The following is a description of a gene set: Little is known about how differentiating cells reorganize their cellular structure to perform specialized physiological functions. MIST1, an evolutionarily conserved transcription factor, is required for the formation of large, specialized secretory vesicles in gastric zymogenic (chief) cells (ZCs) as they differentiate from their mucous neck cell progenitors. Here, we show that MIST1 binds to highly conserved CATATG E-boxes to directly activate transcription of genes, including those encoding the small GTPases RAB26 and RAB3D. We next show that RAB26 and RAB3D expression is significantly downregulated in Mist1(-)(/)(-) ZCs, suggesting that MIST1 establishes large secretory granules by inducing RAB transcription. To test this hypothesis, we transfected human gastric cancer cell lines stably expressing MIST1 with red fluorescent protein (RFP)-tagged pepsinogen C, a key secretory product of ZCs. Those cells upregulate expression of RAB26 and RAB3D to form large secretory granules, whereas control, non-MIST1-expressing cells do not. Moreover, granule formation in MIST1-expressing cells requires RAB activity because treatment with a RAB prenylation inhibitor and transfection of dominant negative RAB26 abrogate granule formation. Together, our data establish the molecular process by which a transcription factor can directly induce fundamental cellular architecture changes by increasing transcription of specific cellular effectors that act to organize a unique subcellular compartment. from publication Tian X, Jin RU, Bredemeyer AJ, Oates EJ, Błazewska KM, McKenna CE, Mills JC (PMID 20038531) Genes up-regulated in both AGS and HGC-27 cells (gastric cancer) by BHLHA15 transfection. Human Gene Set: TIAN_BHLHA15_TARGETS species: Homo sapiens, and this is the list of marker genes: ARRDC3, SLC31A2, MPC1, RAB3D, MAP2K5, DISP1, ACP2, FIGN, CCPG1, RAB26, AQP3, MINDY1, SERPINI1, C2orf88, FNDC3A, TIFA